The following is a description of a gene set: Any process that results in a change in state or activity of a cell (in terms of movement, secretion, enzyme production, gene expression, etc.) as a result of a fructose stimulus. Mouse Gene Set: GOBP_CELLULAR_RESPONSE_TO_FRUCTOSE_STIMULUS species: Mus musculus, and this is the list of marker genes: Slc2a5 (NCBI Gene Id 56485), Pck1, Slc26a6, Xbp1 (X-box binding protein 1), Ppara